Given this list of marker genes H1f7, Prokr1, Foxs1, Epn3, Tuba3a, Adam33, Cnmd (chondromodulin), Tssk3, Lep, Evpl, S1pr4, Col6a2, Tnfrsf13c, Plekhg4, Eppk1, Ppih, Lyl1, Pak6, Palm3, Nckap5, Mogat1, Krt85, Shank2, Zfp599 (zinc finger protein 599), here is a description of the gene set: Mouse Gene Set: MEISSNER_NPC_ICP_WITH_H3_UNMETHYLATED from publication Meissner A, Mikkelsen TS, Gu H, Wernig M, Hanna J, Sivachenko A, Zhang X, Bernstein BE, Nusbaum C, Jaffe DB, Gnirke A, Jaenisch R, Lander ES (PMID 18600261) studied in species Mus musculus Genes with intermediate-CpG-density promoters (ICP) that have no histone H3 methylation marks in neural precursor cells (NPC). DNA methylation is essential for normal development and has been implicated in many pathologies including cancer. Our knowledge about the genome-wide distribution of DNA methylation, how it changes during cellular differentiation and how it relates to histone methylation and other chromatin modifications in mammals remains limited. Here we report the generation and analysis of genome-scale DNA methylation profiles at nucleotide resolution in mammalian cells. Using high-throughput reduced representation bisulphite sequencing and single-molecule-based sequencing, we generated DNA methylation maps covering most CpG islands, and a representative sampling of conserved non-coding elements, transposons and other genomic features, for mouse embryonic stem cells, embryonic-stem-cell-derived and primary neural cells, and eight other primary tissues. Several key findings emerge from the data. First, DNA methylation patterns are better correlated with histone methylation patterns than with the underlying genome sequence context. Second, methylation of CpGs are dynamic epigenetic marks that undergo extensive changes during cellular differentiation, particularly in regulatory regions outside of core promoters. Third, analysis of embryonic-stem-cell-derived and primary cells reveals that 'weak' CpG islands associated with a specific set of developmentally regulated genes undergo aberrant hypermethylation during extended proliferation in vitro, in a pattern reminiscent of that reported in some primary tumours. More generally, the results establish reduced representation bisulphite sequencing as a powerful technology for epigenetic profiling of cell populations relevant to developmental biology, cancer and regenerative medicine.